The following is a description of a gene set: studied in species Homo sapiens Human Gene Set: REACTOME_FORMATION_OF_APOPTOSOME Formation of apoptosome, and this is the list of marker genes: APIP, DIABLO, CASP9, MAPK1, XIAP, AVEN, UACA, CYCS, APAF1, MAPK3, CARD8